Given this list of marker genes Steap4, Mtrr, Steap3, Steap2, Mmachc, Steap1, here is a description of the gene set: Mouse Gene Set: GOMF_OXIDOREDUCTASE_ACTIVITY_ACTING_ON_METAL_IONS_NAD_OR_NADP_AS_ACCEPTOR species: Mus musculus Catalysis of an oxidation-reduction in which the metal ion is reduced and NAD+ or NADP+ acts as an electron acceptor.